The following is a description of a gene set: Auto-amputation is the spontaneous detachment of an appendage from the body due to long standing pathology. Human Gene Set: HP_AUTOAMPUTATION Autoamputation studied in species Homo sapiens, and this is the list of marker genes: TRPV3 (transient receptor potential cation channel subfamily V member 3), WNK1, ATL1, TGM1, RAB7A, TREX1, KIF1A, KRT1, GJB2 (gap junction protein beta 2), RETREG1, SPTLC1, SCN9A, VPS33B, SPTLC2, SLURP1, NTRK1, MPV17